The following is a description of a gene set: Any process that modulates the frequency, rate or extent of cortisol biosynthetic process. Human Gene Set: GOBP_REGULATION_OF_CORTISOL_BIOSYNTHETIC_PROCESS species: Homo sapiens, and this is the list of marker genes: H6PD, REST, BMP5, BMP2, DKK3, WNT4, DGKQ